The following is a description of a gene set: Mouse Gene Set: MIR_335_3P from publication Chen Y, Wang X (PMID 31504780) Genes predicted to be targets of miRBase v22 microRNA mmu_miR_335_3p in miRDB v6.0 with MirTarget v4 prediction scores > 80 (high confidence targets). studied in species Mus musculus, and this is the list of marker genes: Tmem30a, Cd2ap, Zbtb18, Cmtr2, Plxdc2, Spmip4, Khdrbs1, Aass, Brox, Stxbp5, Dlk2, Ncoa5 (nuclear receptor coactivator 5), Rab39b, Pabpc4l, Atxn7 (NCBI Gene Id 78432), Lifr, Trub1, Lrp2, Psmd14, Atrnl1, Chl1, Hccs, Zfp979, Far2, Jade1, Mycn, Neurog1, Twf1, Acvr1c, Agps, Tdrp, Grpr, Arhgap32, Gpr180, Ift70b, Crlf3, Palld, Angpt1, Chit1, Tmem135, Slc24a2, Trp63, Irf6, Cdc37l1, Ntrk2, Zfp36l2, Scfd2, Tmeff2, Nek1, Tmed5, Tmem33, Jcad, Eif4b, Agmo, Shroom3, Epha7, Hhip, Slc25a17, Plod2, Herc6, Vps37d, Wnt3, Akap8, Elapor2, Edil3, Gabrb3, Yme1l1, Rps6kb1, Cep135, Edem3, Steap2, Marchf7, Cdc73, Wdr37, Stmn2, Tbc1d12, Klhl34, Osbpl8 (NCBI Gene Id 319994), Amy2a4, Tbca, Lmo7, Ggh, Gucy1a2, Angptl1, Tmem100, Fam98a, Syt4, Rapgef4 (NCBI Gene Id 71744), Hlcs, Phf24, Ube2d2b, Gid8, Ppm1k, Brcc3, Eif1a, Rbl2, Fgf18, Cadm2, Dcun1d1, Gpr85, Pate9, Nexmif, Kctd12b, Smagp, Ank3, Crispld2, Tra2b, Gzf1, Krtap13 (keratin associated protein 13), H60c (NCBI Gene Id 74031), Zbtb10, Mfsd8, Msi2, Sult1d1, Fbxw7, Hepacam2 (NCBI Gene Id 209089), Ppp3ca, Poc1b, Kdm1a, Cpeb4, Tasor, Zbtb11, Tmem237, Zfp68, Guf1, Cntn1, Xndc1, Pcdh20, Itgb2, Rab1a, Itga8, Lrrtm3 (NCBI Gene Id 216028), Stag1, Hdgfl2, Hycc2, Tceal1, Ptger2, Sim1, Zcchc24, Rap2b, Gga1, Mrpl39, Cep350, Sema3e, Zfp735, Slco1a4, Tm7sf3, Lcorl, Crp, Ambra1, Lrp11, Thrb, Abi1, Ttf1, Smarce1, Il1rapl2, Rp2, Zfp654, Ccr9, Atl2, Barhl2, Larp4, Pbrm1, Ehf, Mfsd6, Ppargc1a, Ank1, Sox9, Rc3h1, Tmem181a, Abhd18, Pabpc5, Chd9, Usp34, Otud1 (NCBI Gene Id 71198), Mdm1, Taok3, Kpna4, Naaladl2, Or5m3b, Pgm2l1, Mex3a, Ankrd44, Lrriq4, Trabd2b, Nudcd2, Or51ab3, Elavl2, Dkk2, Rasgrp3, Thsd7a, Rest, Bag1, Ppat, Atp6v1a, Akap7, Pabpn1, Kcnc2, Tfcp2l1, Zic3, Socs3, Hnrnpa3, Asxl3, Dyrk1a, Cacnb4, Tent5a, Homer1, Ccl11, Jmy, Acvr2a, Zfp39, Mbtps2, Esr1, Col19a1 (collagen, type XIX, alpha 1), Zfp867, Acbd5, Npas3, Napg, Pfpl, Ccn3, Fam178b, Necab1, Slco2b1, Slc36a4, Txlng, Zcchc2, Tbc1d9, Megf10, Spry2, Creb5, Pax3, Pgap1, Nipa1, Slc17a8, Kat2b, Sytl5, Fmn2, Per1, Dner, Sntg1, Hoxa10, Sulf2, Tjp1, Osbpl11, Lrrc40, Sema3d, Slc38a6, Scai, Amy2a3, Nppc, Erc2, Prrx1, Elac1, Flrt3, Crebrf, B3gnt8, Tmprss11e, Pum2, Zbtb21, Cntrl, Esco2, Ugt2b36, Tsc22d2, Unc80, Dscaml1, Cryzl1, Alkal2 (ALK and LTK ligand 2), Tmtc3, Strn4 (NCBI Gene Id 97387), Pakap, Tspan12, Ube2t, Nkain3, Pou3f2, Slc9a2, Papolg, Ptgs2, Toe1, Egr3, Pclo, Dab1, Lrguk, Atad5, Bcor, Ccdc126 (coiled-coil domain containing 126), Tshz1, Gorab, Spn, Eya1, Srpk2, Dach1, Ly86, Kcnb1, Rpgrip1l, Cyp7b1, Klre1, Osgepl1, Zbtb7a, Pten, Hspa1b, Atf2, Plp1, Fgd6, Hcrtr2, Mmp8, Igf1, Qki, Ahr, Rnase4, Pax8, Zdhhc21, Btf3l4, Adgrl2, Dnajc3, Shoc2, Prdm4, Snx7, Dhrs9, Ssr1, Hook3, Arl15, Rab27b, Stc1, Abhd5, Mageb16, Myo6, Ythdf3, Nkx2-2, Dstn (destrin), Clip1, Hibch, Eml5, Ryr2, Sh3kbp1, Adam10, Zbed6, Ppil1, Idh3a, Relt, Diaph1, Rgs7bp, Tmem47, Elp4, Prl4a1, Gabra4, Larp4b, Ankrd33b, Nmt2, Ube2g2, Zfp354a (NCBI Gene Id 21408), Fos, Ippk, Pmpcb, Ptpn3, Fsbp, Prc1, Crispld1, Enpp2, Galnt13, Rictor, Cyria, Ppm1b, Spopl, Fut9 (NCBI Gene Id 14348), Appl1, Col1a2, Taok1, Otud4, Nup37, Nckap1, Rbm7, Rasgef1b, Lrig3, G2e3, Tmtc1, Grin3a, Il1rap, Arhgap17, Tafa2, Rnf14, Igf1r, Amy2a2, Brd1, Tnfsf8, Cnnm1, Wwp1, Adgrl4, Zfp974, Ces2c, Pcdh15, Lmod2, Dnajb5, Cntn3, Astn1, Ppp2r2b, Atp1b4, Etf1, Ttc21b, Zfp317, Micu3, Twsg1, 9330159F19Rik, Chic1, Rap2a, Tmem175, Nrcam, Sp4, Sema3c, Nbeal1, Flywch1, Mapk1, Pkn2, Nsd1, Sult3a1, Nxpe4, Mndal, Kras, Fgf12, Pnpla8, Fmr1, Fubp1, Pcnx1, Stxbp5l, B3gnt5, Uty, Etv1, Ston2, Nt5m, B4galt4, Mybl1, Abca9, Tead1, Atp6v1g1, Zfp655, Ephx3, Samhd1, Cacng2, B3galt2, Chd2, Sbds, Zfp616, Zfp605, Ccnb2, Rasgef1a, Tm2d1 (NCBI Gene Id 94043), Cdk13, Sephs2, Fbxl4, Nars2, Bcl11b, Mindy2, Fzd3, Ttc39b, Fam117b, Phip, Ptger4, Hdac9, Sh2d4a, Kcnq5, Runx1t1, Mbnl3, Kmt5b, Zfp36l1, Magohb, Tox3, Pitx2, Dtd1, Slc25a13, Optc, Mgat4c, Lrrtm2, Ifi44, Ifi202b, Plppr5, Pappa, Zfp449, Clcn4, Gmcl1, Tigd4, S2bpcox16, Ccdc88a, Nufip2, Mmp12, Zc3h12a, Tbk1, Htr7, Flg2 (NCBI Gene Id 433620), Gabrb1, Recql, Atxn3, Cnot2, Zcchc14 (NCBI Gene Id 142682), Slc19a2, Pabpc1, Msr1, Slc1a2, Pdik1l, B230219D22Rik, Tmem19, Brwd1, Spata31e5, Rbm39, Nav1, Ufl1, Rab33b, Map3k2, Zc3h14, Smpd4, Esp36, Uggt1, Cox16, Tab3, Myo1b, Tmem106b, Prtg, Ankrd49, Pou2f1